The following is a description of a gene set: species: Mus musculus Genes predicted to be targets of miRBase v22 microRNA mmu_miR_7033_5p in miRDB v6.0 with MirTarget v4 prediction scores > 80 (high confidence targets). Mouse Gene Set: MIR_7033_5P from publication Chen Y, Wang X (PMID 31504780), and this is the list of marker genes: Peg10, Dhcr7, Grin2b, Cdr2l, Socs7, Pkn2, Disp3, Thsd4, Cdc25a, Dock5, Zfp609, Shisa9, Papola, Tcp10b, Tmem8b, Cimip3, Zfp442, Gpr119, Vps4a, Nipal4, Scn8a, Ankrd33b, Lce3c, Phf24, Cdc42se1, Ifi208, Slc35g1, Carhsp1, Aph1a (NCBI Gene Id 76226), Zdhhc8 (zinc finger, DHHC domain containing 8), Ly6i, Slc6a17, Ly6c2, Agap1, Scai, Chd5, Zfp936, Plagl2, Marchf9, Tacc1 (transforming, acidic coiled-coil containing protein 1), Map4k2, Tmem207, Tacr1, Tcp10a, Mdfic, Psme3, Vxn, Aqp9, Gm10220, Mdm2, Cmtr1, Pgap1 (NCBI Gene Id 75976), Grhl2, Orai2, Dynll2, Epha4, Zfp97, Pla2g12a, Gm6712, Lair1, Rpl39, Sfpq (NCBI Gene Id 78315), Dll3, Kcnq2, Lipg, Zfp994, Lce3d (late cornified envelope 3D), Vamp1, Pgf, Csmd2, Mrfap1, 9930012K11Rik, Syce1, Mynn, Sertad4, Zfp521, Syn3, Mtcl2, Ccdc177, AW209491, Szt2, Paxip1, Map3k3, Rab11fip1, Ptgr2, Tcp10c, Phc1, Zfp960, Ctnnbip1, Dnmt3a, Zfp410, Slc6a3, Zcchc24, Zfp935, Dnajb12, Slc22a21, Tmem170b, Rflnb, Zswim9, Myrf, Acp7, Krt4, Cd276, Ppm1h, Zfp976, Cxxc5, Kpna6, Adgrl1, Klre1, Gins3 (NCBI Gene Id 78833), Fbf1, Tmem132b, Aoc3, Ar, 2310030G06Rik, Fadd, Crb2, Mroh1, Rragc, Kif1a, Insyn2b, Arpp21, Ly6c1, Zfp1008, Cutal, Lsm2, Abcg4, Brf1, Slc1a5, St8sia4, Zfp429, Impact, Dennd6b, Mxd4, Npnt, Zfp781b, Tbx4, Adra2b (adrenergic receptor, alpha 2b), Ccny, Chst2, Atg13, Adamts14, Yipf6, Rock2, Zfp169, Zfp275, Pced1a, Pfkfb2, Cdx1, Rpain (RPA interacting protein), Jam3, Plek2, Aatk, Prmt8, Prss33 (NCBI Gene Id 353130), Fry, 5031410I06Rik, Wnt9b, Zfp947, Padi1, Zswim6, Gnai2, Dctn5